The following is a description of a gene set: Human Gene Set: GOBP_ACID_SECRETION species: Homo sapiens The controlled release of acid by a cell or a tissue., and this is the list of marker genes: NF1, SNX10, GABBR1, TRPC4, APBA1, TNF, BEST1, KCNQ1, HRH2, ABCB11, SLC51B, SGK1, NMU, SLC26A6, CCKBR, NTSR1, CLDN2, CASR, ABAT, HIP1R, MIR33A, CACNB4, UMOD, DRD2, SLC51A, P2RX7, AGXT, CES1, SLC26A7, SLC22A16 (NCBI Gene Id 85413), SLC9A4, GHRL, CHRM5, DRD3, TRH, NHERF1, ABCB4 (NCBI Gene Id 5244), UGT1A3, ACACB, SCT, PTGER3, TFF2